Given this list of marker genes Dynll1, Rab3ip, Dennd2a, Rab35, Gja1, Kif18b, Ubb, Cyth3, Syt9, Arf6, M6pr, Ldlr, Ctsc, Cd55, Tgfa, Gjb5, Sec24a, Sptbn4, Sbf1, Stx4a, Calr (calreticulin), Dtnbp1 (NCBI Gene Id 94245), Igf2r, Ap1s3, Gcc1, Rab27b, Ap2b1, Copb1, Rab18, Apoa1, Agpat3, Ubqln2, Sec16b, Snf8, Cops6, Rab30, Gabarap, Gjd2, Dennd4b, Sparc, Lrp1, Rab36, Tbc1d10a, Grk3, Dennd1c, Slc2a8, Kif26a, Rab3gap2, Ap4s1, Ap1b1, Sec31a, Syt8, Klc3, Alpi, Bicd2, Tmed10, Tbc1d17, Tacr1, Epgn, Dnajc6, Cog7, Rab39b, Stab2, Pafah1b3, Rab9b, Nsf, Trappc9, Cpd, Copb2, Hsp90b1, Mon1a, Tmed9, Rab1a, Vamp8, Chrm2, Ap1s1, Pacsin2, Usp6nl, Rab10, Gjb2, Dennd2b, Hpx, Tbc1d13, Ap2s1, Dctn6, Pik3c2a, Btc, Apol7e, Masp1, Trappc5, Tubb4a, Dennd6a, Pla2g6, Vps54, Rab7, Stam, Reps1, Gak, Tbc1d15, Rab21, Tubb6, Mvb12a, Dennd5b, Kdelr1, Gja3, Apol11b, Col7a1, Ins1, Rab4a, Egfr, Cog8, Uso1, Sh3gl3, Apoe, Tubb2b, Cd3g, Cenpe, Rab1b, Arpc5, Arf1, Hbb-bt, Lman1l, Ccz1, Amph, Golga2, Ap2m1, Stx18, Vamp4, Folr1, Rab6a, Ap3s1, Bloc1s1, Cd3d, Apol9b, Cd36, Tuba8, Rps27a, Actr10, Chmp5, Sec31b (NCBI Gene Id 240667), Arpc2, Syt1, Prdx1, Ap1m1, Rab32, Ap1g2, Apol7b, Golga4, Actr2, Gorasp1, Arcn1, Klc4, Picalm, Fth1, Apol10b, Cd163, Snap29, Hip1r, Rab38, Cnih2, Igll1, Necap1, Kif1b, Kdelr3, Chmp2a, Epn1, Ins2, Tbc1d7, Colec11, Rin1, Tubb4b (tubulin, beta 4B class IVB), Copg1, Cyth4 (NCBI Gene Id 72318), Yipf6, Optn, Areg, Actr3, Ocrl, Lman2l, Itsn1, Copg2, Apol8, Tbc1d24, Rab33a (RAB33A, member RAS oncogene family), Cbl, Trappc8, Dvl2, Chmp2b, Kdelr2, Arrb2, Sptbn2, Bin1, Pip5k1c, Rab39, Dnm2, Gja4, Rabgap1, Dnase2a, Tuba4a, Tuba1a, Tbc1d2, Scfd1, Rab5c, Arfip2, Gdi1, Tuba3b, Kif2c, Dync1li2, Bet1, Tmed3, Arfgap2, Actr1a, Fcho2, Synj2, Tuba1b (tubulin, alpha 1B), Rab11a, Vps37d, Kif20a, Gjd3, Sec24d, Kif21a, Vamp2, Tpd52l1, Alb, Sec24b, Gdi2, Tubal3, Rab3a, Kif2b, Gjb4, Map1lc3b, Dctn1, Vps37c, Snx2, Fzd4, Ywhae, Apob, Trf, Arpc4, Clvs2 (clavesin 2), Cnih3, Racgap1, Hmgb1, Tsg101 (NCBI Gene Id 22088), Ulk1, Cltb (NCBI Gene Id 74325), Nbas, Kif27, F8, Plin3, Tsc1, Arf5, Kifap3 (kinesin-associated protein 3), Kif9, Msr1, Ubap1, Gabarapl2, Rint1, Hp, Nedd8, Rab8a, Rabgef1, Pum1, Snx9, Snap91, Lman1, Apol10a, Apol9a, Eps15l1, Dennd6b, Tor1a, Trip10, Avpr2, Bloc1s3, Kif3c, Galnt1, Kif12 (kinesin family member 12), Ank1 (NCBI Gene Id 11733), Kif5b, Apol7a, Cyth1, Rab8b, Ap2a1, Ppp6c, Grb2, Avp, Tuba1c, Ambp, here is a description of the gene set: species: Mus musculus Reactome Pathway: Vesicle-mediated transport This event has been computationally inferred from an event that has been demonstrated in another species.<p>The inference is based on the homology mapping from PANTHER. Briefly, reactions for which all involved PhysicalEntities (in input, output and catalyst) have a mapped orthologue/paralogue (for complexes at least 75% of components must have a mapping) are inferred to the other species. electronically inferred by orthology from the curated human pathway